Given this list of marker genes SPI1, FCGRT, COL16A1, PGGHG, DTNA, FGFR1, TMEM222, COMMD4, FADS2, PEX5L, TNFAIP3, TIE1, GDI1, ANGPT1, TRIM47, RGS12, SLC22A3, PADI4, GABARAPL1, FGD5, TOX, CARM1, SSTR3, AGPAT2, SYT2, FAM184B, MAP1LC3A, NFIC, ADGRL4, CSRNP1, TSSC4, PHKG2, GBA2, GLT8D2, POLE3, COMMD3 (COMM domain containing 3), SKIC2, CHRNA6, ARMC7, PDLIM2, ERN2, ESAM, RRP1, UBXN6, TBRG1, RAB38, CNPY3, MYCT1, RPS6, MAP2K2, ABCA2, RUNX2, LETM2, NRIP1, PBX4, BRD2, CAVIN3, NRM, BATF2, LARGE2, WIPI2, PHKG1, HMG20B, DNTT, AKAP8L, ATF4, CPVL, KTI12 (NCBI Gene Id 112970), PHLDA2, ZFHX3, PRKAG1, NFE2, ATAT1, SDSL, GEMIN7, NRROS, CCND3, BTRC, PSENEN, TRAPPC9, PRR36, TBXAS1, EBF3, PRRC2C, ZNF414, DDX39B, DUSP4, SCN3B, COMT, CNOT6L, MSI2, SAPCD1, MUSTN1, LCE2B, HLA-DOB, FTH1, GNG2, C5orf15, UQCR11, PHOX2B, DELE1, LTBR, TONSL, DALRD3, RFC2, RPL30, SOCS3 (suppressor of cytokine signaling 3), CERS4, WBP2, TTC39B, SLC12A7, F2R, SCRN2, GTPBP1, PPP1R17, SGSH, CIRBP, DAPP1, BZW2, MUC13, RPS29, KDM6B, PRAF2, TMUB1, TFR2, SMAGP, KRT18, CTSD (cathepsin D), POLR3D, JAG2, PLA2G12A, HSPA12B, REX1BD, RNF180, PCED1A, CISH, ATP11B, ALDH7A1, MRPS21, IPO4, HMGB3, GGN, MBD6, KBTBD11, PDE9A, BAMBI, RHBDD2, TRPC4AP, DEXI, PLK3, TLN1, WIPI1, STAT4, UBE2S, CHERP, CSGALNACT1, TLCD4, FYB1 (NCBI Gene Id 55458), CSDC2, APPL2, ICAM2, GATAD1, MAP4K1, FZD8, LZTS2, RALYL, ARHGEF39, EHMT2, PLD2, NEXMIF, RPLP0, ARHGAP33, ADIPOR2, FLT4, FRG1, IRGQ, ACO2, PLSCR4, ANKRD13A, BEST1, CYP2J2, HPCA, AAAS, SYT1, ZNF23, RAB10, NAPRT, SLC25A23, GKAP1, APOE, RING1, ISG20, KLF6, SELENOW, SENP6, RABAC1, CEL, TMEM37, PML, here is a description of the gene set: Genes up-regulated in allogeneic T cells after stimulation with dendritic cells from: liver versus peripheral lymph nodes (pLN). Transcriptional response of murine allogeneic T cells (B10.BR) after stimulation with different organ-derived (spleen, liver, peripheral and mesenteric lymph nodes) dendritic cells (C57BL/6) in vitro Human Gene Set: GSE5503_LIVER_DC_VS_PLN_DC_ACTIVATED_ALLOGENIC_TCELL_UP from publication Kim TD, Terwey TH, Zakrzewski JL, Suh D, Kochman AA, Chen ME, King CG, Borsotti C, Grubin J, Smith OM, Heller G, Liu C, Murphy GF, Alpdogan O, van den Brink MR (PMID 18178870) species: Homo sapiens